The following is a description of a gene set: species: Homo sapiens Genes down-regulated in comparison of untreated CD4 T cells versus the untreated CD8 T cells. To elucidate the gene expression “footprint” of antigenically challenged T-cells which had been treated with anti-LFA-1, CTLA4Ig, anti-CD40-ligand antibodies, we performed microarray gene expression analysis comparing the expression profile of costimulatory blockade treated and untreated responder T-cells. from publication Pearl JI, Lee AS, Leveson-Gower DB, Sun N, Ghosh Z, Lan F, Ransohoff J, Negrin RS, Davis MM, Wu JC (PMID 21362570) Human Gene Set: GSE26669_CD4_VS_CD8_TCELL_IN_MLR_DN, and this is the list of marker genes: ZNF282, RNF125, GOT1L1, HSD17B14, LIMD1, PTPRC, PIK3CG, CIMIP1, TTLL12, MTIF3, ZBED3, WNT10B, SLC2A4, SOD2, MRPL45, SCNN1A, LZTS2, IL6ST, SIRT6, STRADA, MTA3, KRT81, SCML4 (NCBI Gene Id 256380), SLIT2, NXNL2, SAAL1, LRPPRC, WASHC3, CDC42EP3, PPP3CA, EFCAB7, SEMA3C, GPR68, TUBA1A, PIK3R1, OXNAD1 (NCBI Gene Id 92106), SSMEM1, FLNB, LPAR6, RP9, BEND5, PLTP, TBC1D31, MEIS1, GGT1, MIB2, RRP36, PTCH1, GBF1, SMKR1, DDN, SIPA1L3, EIF2A, THBS3, KALRN, CARF, PRKAR2A, GOLM2, MRPL24, IDH3A, PEPD, SV2A, CAPNS2, PRKCH, SUN2, DAGLB, MARVELD1, CENPQ, NDNF, RNF185, PECR, TXNL4B, METTL27, CUEDC1, AP3M2, ZNF839, TSPY1, PALD1, MCTP2, FHIT, DHX16, TMEM74B, PEX2, EYA2, RSPH6A, KRT26, SURF1, ATXN7L3, UTP4, GSTCD, TIMM10, ACER1, SHMT2, ALKBH5, SCO1, KLRC3, SNHG8 (NCBI Gene Id 100093630), PER3, UBE3A, MOSMO, ZNF827, ITCH, BLZF1, SLC6A19, GEMIN5, AHNAK, B4GALT1, GPX8, SLA2, MYLIP, MBD4, CHST7, SLC9A9, PSPH, DCAF17, GABPA, CCDC102A, OSBPL8 (oxysterol binding protein like 8), MIGA1, KLHL28, TIRAP, DMAC1, CD3G, MCOLN2, PLAC8, GLE1, NOB1, NIPA1, CCDC28B, ABCB6, TPRG1L, CD164, UFL1 (NCBI Gene Id 23376), CHAC1, MC3R, CASR, GAB3, FNTB, SV2C, MCUR1, ACTN1, GTF3A, ART4, ADIPOR1 (adiponectin receptor 1), RPL14, PTEN, TBXA2R, DNAJC3, TSPAN9, CRACDL, SLC25A16, ALG8, RCL1, AXDND1, CLYBL, NAA38, MAN1A1, SNRPD3, P2RX5, SF3B5, DPY19L1, LPXN, HILPDA, TAF13, ZZEF1, BPNT2, CTU1, STYX, EGLN3, LIMK1, PRKN, PAX1, SLC16A6, SEPTIN1, GPN3, KLHL42, UMOD, DENND4C, PRKCB, IGF2R, HSCB, SLC49A4, SNAI3, PLCXD2, CHIC2, DCAF12, LYPD6B, DGUOK, VSIR, ZBTB8A, ZSCAN22, SEMA4A, PDPK1, OTULIN, DOCK10, BACH1, MFSD2B, OAS3, TUSC2